The following is a description of a gene set: Genes up-regulated in pre B lymphocyte after induction of physiological DNA double-strand breaks (DSB) by RAG2; the changes depend on ATM but not NFKB signaling. from publication Bredemeyer AL, Helmink BA, Innes CL, Calderon B, McGinnis LM, Mahowald GK, Gapud EJ, Walker LM, Collins JB, Weaver BK, Mandik-Nayak L, Schreiber RD, Allen PM, May MJ, Paules RS, Bassing CH, Sleckman BP (PMID 18849970) studied in species Mus musculus DNA double-strand breaks are generated by genotoxic agents and by cellular endonucleases as intermediates of several important physiological processes. The cellular response to genotoxic DNA breaks includes the activation of transcriptional programs known primarily to regulate cell-cycle checkpoints and cell survival. DNA double-strand breaks are generated in all developing lymphocytes during the assembly of antigen receptor genes, a process that is essential for normal lymphocyte development. Here we show that in murine lymphocytes these physiological DNA breaks activate a broad transcriptional program. This program transcends the canonical DNA double-strand break response and includes many genes that regulate diverse cellular processes important for lymphocyte development. Moreover, the expression of several of these genes is regulated similarly in response to genotoxic DNA damage. Thus, physiological DNA double-strand breaks provide cues that can regulate cell-type-specific processes not directly involved in maintaining the integrity of the genome, and genotoxic DNA breaks could disrupt normal cellular functions by corrupting these processes. Mouse Gene Set: BREDEMEYER_RAG_SIGNALING_VIA_ATM_NOT_VIA_NFKB_UP, and this is the list of marker genes: Acer3, Kif17, Zfp182, Pkd2, ENSMUSG00000144058, Siva1, Cyp2j9, Prrg4, Map3k8, Camk2b, Igf2bp3, D17H6S56E-5, Hook1 (hook microtubule tethering protein 1), Dipk1a, Ift81, Fggy, Neurl3, Snrnp25, Trim68, Thbd, Zfp579, Crim1, Bcl11a, Cldn34c1, Colec12, Dusp16, Akr1e1, Rab39, Cib1, Retreg1, Cybb, Iftap, Sell, Jun, Tmem71, Msrb2, Kif16b, Nfix, Il6st, Golm1, Ldlrad3, Sh2d5, Kcnk6, Nat2, Dock7, Csrp2, Csgalnact1, Anxa4, Smo, Tcaim, Pepd, Qsox1, Ltb, Slc20a1